The following is a description of a gene set: A process that modulates short-term neuronal synaptic plasticity, the ability of neuronal synapses to change in the short-term as circumstances require. Short-term neuronal synaptic plasticity generally involves increasing or decreasing synaptic sensitivity. studied in species Mus musculus Mouse Gene Set: GOBP_REGULATION_OF_SHORT_TERM_NEURONAL_SYNAPTIC_PLASTICITY, and this is the list of marker genes: Cln3, Unc13b, Syap1, Gsg1l, Rab3gap1, Grik1, Rab3a, Shisa6, Unc13a, Syngr1, Shisa8, Slc4a10, Shisa9, Syn1, Atp1a3, Slc8a2, Ppfia3, Kmt2a, Bdnf, Syp, Grik2, Syt4 (NCBI Gene Id 20983)